The following is a description of a gene set: studied in species Mus musculus from publication Tabula Muris Consortium (PMID 32669714) Mouse Gene Set: TABULA_MURIS_SENIS_PANCREAS_PANCREATIC_POLYPEPTIDE_CELL_AGEING, and this is the list of marker genes: Stub1, Trappc5, Sdhc, Prr13, Map1lc3a, Try4, Snrpa, Rrm2b, Tceal3, Selenos, Sdf2l1, Pcbp3, Ssna1, C1d, Nudt16, Elp5, Tprkb, Mphosph6, Papss2, Zbtb7c, Sdr39u1 (NCBI Gene Id 654795), Hdgf, Prelid1, Pgd, Tmem219, Foxa3, Ppp5c, Sobp, Ubb-ps, Med6, Klc3, Mmp24os1, Ppp1r11, Cela2a, Klf13, Chd1, Ptms, Rab3a, Fkbp8, Gng10, Cotl1 (NCBI Gene Id 72042), Ssbp4, Cstf1, Emc10, Arhgdia, Syn2, Fos, Clps, Arpc3, Spcs2, Trappc6b, Ppp1ca, Bsg, Cbr1, Lsr, Pnrc1, Sf3b2, Bace2, Gab1, Calm2, Lamtor1 (NCBI Gene Id 66508), Drap1, H3f3b, Mtif2, Smarcb1, Samd4b, Ifitm2, Jmjd6, Mmadhc, Lsg1, Celsr3, Prss3b, Dnajb1, Agtrap, Pdhb, Alkbh6, Ier2, Ociad1, Nsfl1c, Stmn3, Abhd17a, Naa80, Tex261, St13, Psmb4, Kdelr1, Ppa2, Ilkap, Cfap298, Abcf1, Ssb, Pebp1, Lrig1, Tagln2, Jund, Erlec1, Rab12, Tle5, Ppa1, Ube2a, Ctnnbl1, Ubb, Casz1, Gal3st1, Mydgf, Prdx1, Szt2, Cfl1, Rbm25, Shisa5, Fn3k, Srm, Ptma, Blcap, Pofut1, Mospd3, Tsc22d1, F8a, Dusp1, Jtb, Tceal9